Given this list of marker genes SHMT1, GUK1, RRM2B, DCTD, TYMS, CMPK2, DGUOK, AK5, DTYMK, RRM2, DUT, ADK, RRM1, TBPL1, DCK, here is a description of the gene set: Human Gene Set: GOBP_DEOXYRIBONUCLEOTIDE_BIOSYNTHETIC_PROCESS studied in species Homo sapiens The chemical reactions and pathways resulting in the formation of a deoxyribonucleotide, a compound consisting of deoxyribonucleoside (a base linked to a deoxyribose sugar) esterified with a phosphate group at either the 3' or 5'-hydroxyl group of the sugar.